The following is a description of a gene set: species: Homo sapiens Human Gene Set: HP_PERIPHERAL_RETINAL_DEGENERATION Peripheral retinal degeneration, and this is the list of marker genes: P3H2, RS1, CFI, CFH, KCNJ13, COL2A1, POU3F4, EFEMP1, BMP4